Given this list of marker genes IGF1, GRB10, SNX1, IGF1R, IRS1, PHIP, APP, IGF2, CCDC88A, PIK3R1, INSL3, SNX2, ENPP1, SHC1, IRS2, IRS4, SORBS1, LMBRD1, INS, PTPN1, PTPN11, SNX4, here is a description of the gene set: studied in species Homo sapiens Binding to an insulin receptor. Human Gene Set: GOMF_INSULIN_RECEPTOR_BINDING